The following is a description of a gene set: The chemical reactions and pathways involving the ammonium ion. studied in species Homo sapiens Human Gene Set: GOBP_AMMONIUM_ION_METABOLIC_PROCESS, and this is the list of marker genes: ALDH2, TPH2, DDC, RNF180, SULT1A4, SRD5A1, CHDH, HNMT, TRH, ALDH7A1, ATP7A, PRG3, BTBD9, GRIN2A, SULT1A3, TPH1, SLC29A4, HDC, ENPP6, SLC22A3, DMGDH, BCHE, HTR1A (NCBI Gene Id 3350), SLC44A1, PDE1B